Given this list of marker genes Lhx6, Dact1, Mybpc1, D130043K22Rik, Pgm3, Rpgrip1l, Rc3h1, Zfp105, Slfn14, Ndufs4, Mxi1, Wnk3, Shprh, Vezf1, Tmem88, Lurap1l, Zc3h7b, 6030498E09Rik, Exph5, Grap, Mtmr3, Havcr1, Kras, Krt76, Plagl1, Srsf1, Ccl27a, Abi1, Sema7a, Fcgr4, Spopfm2, Arih1, Epha3, Dab2, Syn1, Txlnb, Tmigd3, Tomm22, Akap11, Zfp143, here is a description of the gene set: Genes predicted to be targets of miRBase v22 microRNA mmu_miR_7080_5p in miRDB v6.0 with MirTarget v4 prediction scores > 80 (high confidence targets). Mouse Gene Set: MIR_7080_5P species: Mus musculus from publication Chen Y, Wang X (PMID 31504780)